The following is a description of a gene set: Human Gene Set: HP_ADRENOCORTICOTROPIN_DEFICIENT_ADRENAL_INSUFFICIENCY species: Homo sapiens Adrenal insufficiency secondary to a defect in ACTH production. Adrenocorticotropin deficient adrenal insufficiency, and this is the list of marker genes: NFKB2, CDH23 (cadherin related 23), MEN1, RBM28, TBX19, AIP